Given this list of marker genes Hprt1, Xdh, Urah, Aprt, Acp3, Gda, Kdm1a, Paics, Urad, Shmt1, Dpyd, Prps1, Nt5c2, Gart (NCBI Gene Id 14450), Gmpr, Ada, Adk, Ppat, Ttr, Uox, Pnp, Gmpr2, here is a description of the gene set: The chemical reactions and pathways involving purine nucleobases, one of the two classes of nitrogen-containing ring compounds found in DNA and RNA, which include adenine and guanine. studied in species Mus musculus Mouse Gene Set: GOBP_PURINE_NUCLEOBASE_METABOLIC_PROCESS